Given this list of marker genes DNAJB1, RRM2, PNRC1, DHRS2, SDC4, PRKRA, GRN (granulin precursor), LYPLA2, NEAT1, NIPSNAP1, TGM2, PKM, ZBED3, ID3, USB1, RHOA, TPP1, E2F2, HLA-DQA1, CYP4F2, HADHB, PIP4P1, GNB1, H3-3B, CCN2, CLU, ANAPC13, OPTN, ID2, BSCL2, PRPF3, STAT1, CDKN1A, TXNRD1, CCN1, BSG, PRDX1, SQSTM1, DUSP1, STX6, ZDHHC9, H1-0, IFITM3, ATP6AP2 (ATPase H+ transporting accessory protein 2), JMJD1C, here is a description of the gene set: Genes up-regulated in more than one of several human hepatoma cell lines by TSA. studied in species Homo sapiens Human Gene Set: CHIBA_RESPONSE_TO_TSA from publication Chiba T, Yokosuka O, Arai M, Tada M, Fukai K, Imazeki F, Kato M, Seki N, Saisho H (PMID 15336447) BACKGROUND/AIMS: Epigenetics is the key factor in the regulation of gene expression. We conducted cDNA microarray analysis to screen for genes induced by histone deacetylase (HDAC) inhibition and examined epigenetic alterations. METHODS: Microarray analysis was performed in six hepatoma cell lines and primary hepatocytes treated with trichostatin A (TSA). mRNA expression of several genes was examined by reverse transcription-polymerase chain reaction in TSA-treated cells and hepatoma samples. Acetylated histones and methylation status in 5'CpG islands was assessed by chromatin immunoprecipitation (ChIP) assay and bisulfite genomic sequencing, respectively. RESULTS: Fifty-seven genes showed greater than 2-fold change after TSA treatment in multiple cell lines. Among them, four genes including p21(WAF1) exhibited substantial induction (greater than 5-fold changes). Decreased mRNA levels of these genes in hepatoma tissues were observed in more than half of patients. ChIP assay, in general, demonstrated a good correlation between mRNA expression and histone acetylation, but only a limited correlation with the methylated DNA in the promoter region. CONCLUSIONS: We identified 57 up-regulated genes by TSA treatment in hepatoma cells and some of them appeared to be cancer-related genes in hepatomas. The alterations in acetylated histones are likely closely associated with gene expression.